The following is a description of a gene set: from publication Pont F, Familiades J, Déjean S, Fruchon S, Cendron D, Poupot M, Poupot R, L'faqihi-Olive F, Prade N, Ycart B, Fournié JJ (PMID 21968650) Genes down-regulated in gamma delta T cells activated by phosphoantigen BrHPP and IL2: 6h versus 7 days. studied in species Homo sapiens Human Gene Set: GSE27291_6H_VS_7D_STIM_GAMMADELTA_TCELL_DN We used microarrays to detail the global programme of gene expression by circulating TCRVgamma9+ gamma delta T cells isolated from healthy individuals,tested either as resting cells or cells activated by phosphoantigen BrHPP and IL-2at an early(+6hrs) and a late (+7days) timepoint. We find that with more “NK cell” genes than alphabeta T cells and more “T cell” genes than NK cells, the circulating TCRVgamma9+ gamma delta T cells cells have a hybrid transcriptome. The gene signature of the activated cells recapitulates their physiological functions: Th1 cytokine, chemokine and cytotoxic activities at first and mitotic activity at later time points. The gene expression pattern of activated normal gamma delta T cells is nevertheless clearly distinctive from that of NK/T and peripheral T cell lymphomas of the gamma delta subtype., and this is the list of marker genes: SLC25A45, GPNMB, NCK1, GPR107, BTN3A1, TGOLN2, RASAL3 (NCBI Gene Id 64926), MAPDA, RBBP6, ABAT, MPEG1, PLEKHO1, FIGN, MTUS1, SENP2, STK33, CASP4LP, LINC00189, LINC00528, ADAMTS15, KCTD21, CADM1, TFE3, LDLRAD4, GGT1, MIR3150BHG, UNC50, DUSP3, TTLL13 (NCBI Gene Id 440307), PCGF3, SLC6A12, TRIB1, AIPL1, SDCBP2-AS1, ECSCR, DCBLD1, C5AR1, MYL10, CXCR4, HSPA6, RGL1, ZNF767P, CHD9, ILKAP, CRHBP, MEPE, TCF4, BOC, PRRG2, ADARB1, CCAR1, TMEM140, UBTD2, JAZF1-AS1, BCL6, PLEKHS1, MCTP1, FAM110D, DVL3 (NCBI Gene Id 1857), LIN7B, GPR137B, NPY4R, SPG7, CIRBP, FCER2, NMU, ZCCHC7 (NCBI Gene Id 84186), CAPS2, TRIM33, FAM13A-AS1, SEC63, SLC7A11, YIPF6, NPL, C11orf54, ERCC8, GGTLC1, DNM3, PABIR3, CSN3, FYN, NCOA2, MON2, C2, RGS1, TREML4, IGF1, C10orf55, FAM13B, CTRL, HAVCR1, RNF175, MTMR3, H4C8, PCDH19 (protocadherin 19), PTGER1, SPATA31C2, FBXW11, SMURF2, DSE, CRY2, AGK, ADAR, ZZEF1, FCGR2B, KANSL3, WDR45B, FLJ12825, NPIPB15, SLC27A1, FGFRL1, CCDC27, RNF4, MZB1, SLX4, KLF6, MRLN, SLC7A5, CCDC150, GASK1B, KNL1, SUMO2, PRDM11, SH2D5, FOXN3-AS2, GOLIM4, MREG, CCDC91, MFN2, PDE4B, MMD, SETD5, PBLD, DNAJC6, RAB3C (RAB3C, member RAS oncogene family), ATP8A1, CBX4, PPIF, ETFBKMT, DMPK, SRARP, ZBTB8A, TCP10L, RABEP2, GSG1L (NCBI Gene Id 146395), HPGD, PCBP1-AS1, C8orf48, PARS2, CCDC17, NTRK2, SYT9, FBXO34, TCF19, PKD1P6, TNFRSF10B, RC3H2, TUBGCP4, SGSM2, C12orf60, PAPPA, C6orf226, NPIPA1, CCSER1, OCLN, TMEM131L, ENSG00000224715, RPE65, SARDH, MOCS2, SKAP2, ITIH4, CTSO, ACTL9 (NCBI Gene Id 284382), SLC17A5 (solute carrier family 17 member 5), APOBEC4, H2BC4, FTH1, ARL1, PKD1P1, CEMIP2, NGLY1, AGBL1, HSD17B12, PGD, MKKS, MC3R